The following is a description of a gene set: Mouse Gene Set: GOMF_SHORT_CHAIN_FATTY_ACID_TRANSMEMBRANE_TRANSPORTER_ACTIVITY studied in species Mus musculus Enables the transfer of short-chain fatty acids from one side of a membrane to the other. A short-chain fatty acid has an aliphatic tail containing fewer than 6 carbons., and this is the list of marker genes: Slc5a8, Slc22a26, Slc22a27, Slc22a29, Slc22a28, Slc22a19 (solute carrier family 22 (organic anion transporter), member 19), Cd36, Slc22a30